The following is a description of a gene set: species: Homo sapiens Abnormal nasolabial region morphology Human Gene Set: HP_ABNORMAL_NASOLABIAL_REGION_MORPHOLOGY, and this is the list of marker genes: MYBPC1, TOR1A, GNB2, DSE, ATP6V1A, C1GALT1C1, MAN1B1 (mannosidase alpha class 1B member 1), ATP6V1E1, NF1, TNNI2, LTBP1, NALCN, NAA10, ATP6V0A2, PGM2L1, SNRPN, CHST14, FOXP1, SPRED2, USP9X